The following is a description of a gene set: Angiopoietin receptor Tie2-mediated signaling Human Gene Set: PID_ANGIOPOIETIN_RECEPTOR_PATHWAY from publication Schaefer CF, Anthony K, Krupa S, Buchoff J, Day M, Hannay T, Buetow KH (PMID 18832364) species: Homo sapiens, and this is the list of marker genes: FOXO1, ITGB1, RAC1, FES, STAT5B, PTK2, ELF2, PIK3CA, ANGPT1, RPS6KB1, ANGPT4, ELK1, FYN, PIK3R1, MAPK14, ETS1 (ETS proto-oncogene 1, transcription factor), MAPK8, ITGA5, NCK1, GRB7, STAT5A, AGTR1, TNF, ANGPT2, GRB14, BMX, AKT1, PAK1, PLG, ELF1, SHC1, MMP2, NOS3, PXN, GRB2, PLD2, PTPN11, FN1, DOK2, RELA, RASA1, MAPK3, TEK, MAPK1, F2, FGF2, CRK, NFKB1, CDKN1A